Given this list of marker genes FBXO7, AMBRA1, BNIP3, PARK7, HTT, NOD2, PRKN, VDAC1, GBA1, VPS13D, HDAC6, MUL1, STUB1, DELE1, CAMKK2, ATP5IF1 (ATP synthase inhibitory factor subunit 1), HUWE1, SLC25A4, IRGM, SLC25A5 (solute carrier family 25 member 5), CDC37, UBE2A, TOMM7, HK2, CERS1, EIF2AK1, PINK1, here is a description of the gene set: studied in species Homo sapiens Any process that activates or increases the frequency, rate or extent of mitochondrion degradation by autophagy. Human Gene Set: GOBP_POSITIVE_REGULATION_OF_AUTOPHAGY_OF_MITOCHONDRION